The following is a description of a gene set: Human Gene Set: GSE41867_DAY6_VS_DAY8_LCMV_CLONE13_EFFECTOR_CD8_TCELL_UP Genes up-regulated in CD8 T effector cells during chronic infection with LCMV-Clone 13: day 6 versus day 8. studied in species Homo sapiens from publication Doering TA, Crawford A, Angelosanto JM, Paley MA, Ziegler CG, Wherry EJ (PMID 23159438) During acute viral infections, naïve CD8+ T cells differentiate into effector CD8+ T cells and, after viral control, into memory CD8+ T cells. Memory CD8+ T cells are highly functional, proliferate rapidly upon reinfection and persist long-term without antigen. In contrast, during chronic infections, CD8+ T cells become “exhausted” and have poor effector function, express multiple inhibitory receptors, possess low proliferative capacity, and cannot persist without antigen. To compare the development of functional memory T cells with poorly functional exhausted T cells, we generated longitudinal transcriptional profiles for each., and this is the list of marker genes: ITGB1BP2, MS4A6A, DCTN3, EPSTI1, PSMB9, CNTROB, IL7R, HLA-B, ZNF449, IFT22, PAK1, STK40, DOK4, ARHGAP33, CDYL2, OAS2, VWA2, TRAPPC1, STX2, ADGRL2, RASA4, GTPBP2, IGSF8, MRPL40, IFITM3, FCER1G, MZT2B (mitotic spindle organizing protein 2B), FBXO33, KIF13B, PI4K2A, COA5, TMEM256, MUSTN1, BHLHE40, ARMC5, WDR13, STAT2, MAPKBP1, RNASEL, CXCL11, HMGA2, CBLB, RBP3, ACOT8, SLC11A1, ANXA1, TMEM219, PLA2G4A, LINGO3, CGAS, AP3M2, DHX57, SH3BGRL (NCBI Gene Id 96022), KRT73, TRAFD1, TMPRSS11D, SLC9A1, MCTP2, CASP7, ENTPD1, MRPS18C, INHBA, TRIM68, TBC1D32, ETFB, NBDY, SIM2, MFSD6L, ETFRF1, EPHB1, PLAC8, NFIA, SELENOH, LYST, QNG1, LRRC74A, PAGR1, ATOX1, ZBP1, NID1, CA2, PAFAH1B3, LMNA, ENPP4, ROGDI, PDE8A, VDAC3, MRPL44 (mitochondrial ribosomal protein L44), IFFO1, DNAL1, DACT2, CSTPP1, ISG20, ITM2B, OAS3, PML, FLOT2, SERTAD3, SHOX2, ICOS, STX11, TEAD1, CMTM8, RMDN1, RHBDF1, BEND6, TALDO1, SIRT6, LGALS9B, MTARC2, DNAJB6, FBXL17, CCND3, CHRNA7, FBXL8 (NCBI Gene Id 55336), HSPG2, FECH, WASF2 (NCBI Gene Id 10163), IFT80, NLRC5, HPF1, IL10RA, NCEH1, SCN5A, UHRF1, RGS12, C9orf152, PDE3B, CXCR3, C14orf119, YPEL4, KRT35, ENG, FER, MARVELD1, LMCD1, LAMTOR4, CCL4, HDAC1, TIMELESS, ADPRM, RAB29, DXO, TNIP1, PPM1K, SEMA4C, PRDX2, GLT8D1, BMP8A, KCNH3, SOX5, MAF, CHCHD5, TSPAN31, PTPN14, PTMS (NCBI Gene Id 5763), NDRG4, IGHMBP2, CLSTN1, SCO1, IP6K1 (NCBI Gene Id 9807), SLFN12L, ATP6V0E1, TPSB2, ADIPOQ, SLIT3, CIAO2B, LPCAT2, NACC2, SPATA13, EPHA8, ZFHX3, CD3G, GOLM1, WDR62, GALNT13, RSPO2, CASP9, FMNL1, RHOC, MYO1F, CENPM, SERPINB6, SNAP47, TOX2, CFAP410, SLC2A8, SCLY, SLC25A22, CASS4, TBX21, IFT25, COX8A, IGBP1, NIT1 (nitrilase 1), HADH, ADAM8, GSTM4, CRYL1, RNF213